Given this list of marker genes MECP2, TMEM150C, FXN, GBX1, POU4F1, here is a description of the gene set: Human Gene Set: GOBP_PROPRIOCEPTION studied in species Homo sapiens The series of events by which an organism senses the position, location, orientation, and movement of the body and its parts. Proprioception is mediated by proprioceptors, sensory nerve terminals found in muscles, tendons, and joint capsules, which give information concerning movements and position of the body. The receptors in the labyrinth are sometimes also considered proprioceptors.